Given this list of marker genes Chd1l, Parp1, Uba52rt, Rnf111, Cul4a, Usp45, Gtf2h4, Ube2i, Cul4b, Rpa1, Gtf2h2, Ercc1, Rps27a, Mnat1, Sumo1 (small ubiquitin-like modifier 1), Cdk7, Gtf2h1, Ercc3, Parp2, Uba52, Ddb2, Ccnh, Ddb1, Ercc4, Rad23a, Xpc, Gtf2h3, Ubb, Ercc2, Ube2v2, Pias1, Rad23b, Pias3, Sumo3, Xpa, Rbx1, Ubc, Cetn2, Ercc5, Ube2n, Rpa2 (NCBI Gene Id 99984), Rpa3, Gtf2h5, Sumo2, here is a description of the gene set: species: Mus musculus Mouse Gene Set: REACTOME_FORMATION_OF_INCISION_COMPLEX_IN_GG_NER Formation of Incision Complex in GG-NER